Given this list of marker genes VAMP8, STX7, VTI1B, STX8, CHRNA7, C8orf44-SGK3, BSND (barttin CLCNK type accessory subunit beta), CLCN2, SGK1, NHERF1, STX1A, SGK3, ANO9, CFTR, here is a description of the gene set: species: Homo sapiens Human Gene Set: GOMF_CHLORIDE_CHANNEL_REGULATOR_ACTIVITY Binds to and modulates the activity of a chloride channel.